Given this list of marker genes Gng7, Tac1, Gnb5, Mapk1, Prokr1, Npsr1, Rgs19, Dgkh, Gnrh1, Cysltr2, Opn4, Tac2, Casr, Gprc6a, P2ry2, P2ry1, Mapk3, Hrh1, F2rl2, Nms, Ntsr2, Rgsl1, Ltb4r1, Rgs2, Gngt2, Gpr68, Ccl9, Chrm5, Btk, Grb2, Hras, Abhd12, Lpar2, Uts2b, Prok1, Avp (arginine vasopressin), Gpr39 (G protein-coupled receptor 39), Oxt, Npffr1, Ccl6, Adra1a, Chrm3, Nmbr (NCBI Gene Id 69412), Sos1, Plcb4, Gnaq, Brs3, Gpr65, Kras, Itpr1, Grpr, Rgs3, Egfr, Gnb3, Dgkz, Adra1d, Trio, Plcb2, Uts2, Rgs18, Htr2b, Rgs17, Anxa1, Trhr, Tbxa2r, Trpc7 (NCBI Gene Id 26946), F2rl3, Agtr1a, Gngt1, Creb1, Gng8, Gnb2, Nts, Prokr2, Grk2, Fpr2, Gast, Lpar4, Rgs1, Mgll, Pik3r1, Rps6ka3, Dgkb, Gng10, Dgkd, Dgka, Pik3ca, Kalrn, Agt, Ffar3 (NCBI Gene Id 233080), Gpr143, Lpar6, Rgs16, Lpar1, Edn3, Ntsr1, Gpr17, Gna11, Daglb, Bdkrb2, Gcg, Grm5, Ltb4r2, Ptger1, Nmur2, Tacr1, Gna14, Mapk7, Ghrl, Itpr3, Trh, Nmur1, Edn2, F2r, Gnb4, Gnrhr, Gpr4, Htr2c, Nps, Itpr2, Ffar2, Dagla, Ptgfr, Ffar4, Xcr1, Nmu, Rgs4, Dgkq, Lpar5, Cck, Kng2, Ednrb, Lpar3, Grp, Npff, Cckar, Adra1b, Cckbr, F2, App, Gpr132, Hcrtr2, Uts2r, Rgs21, Htr2a, Trpc3, Abhd6, Prkce, Hcrt, Edn1, Kiss1, Prkcd, Bdkrb1, Tacr3, Gng5, Ffar1, Prok2 (NCBI Gene Id 50501), Rgs13, Tacr2, Cysltr1, Gng2, Mmp3, Rps6ka1, Gcgr, Xcl1 (chemokine (C motif) ligand 1), Chrm1, Nmb, Ptafr, Prkcq, Dgkg, Gng13, Pmch, Trpc6, Plcb3, Hcrtr1, P2ry10, Ednra, Kiss1r, Arhgef25, Gng4, Rps6ka2, Dgke, Qrfprl, Prkch, Grm1, Npffr2, Hbegf, Avpr1a (arginine vasopressin receptor 1A), Dgki, Qrfp, Dgkk, Ghsr, Gng11, Avpr1b, Gnb1, P2ry6, F2rl1, Pik3r2, Gng3, Oxtr, Plcb1, Gna15, Pik3r3, Mchr1, Rgs5, Gng12, here is a description of the gene set: species: Mus musculus G alpha (q) signalling events Mouse Gene Set: REACTOME_G_ALPHA_Q_SIGNALLING_EVENTS